Given this list of marker genes PASK, MBLAC1, NXPH3, RPS15AP30, CCDC85C (coiled-coil domain containing 85C), ENSG00000257545, LINC02777, PLCD1, LINC01213, RAB35-AS1, TMEM240, PLAGL2, RELB, CES3, ASXL2, SETDB2, CCDC12, LINC01897, VPS13D, SPATA2, ALKBH1, GRB7, RNU6-545P, SCML1, LINC01096, LIMS1, AK8, ENSG00000235978, EPN3, NDUFA3, SLC6A6, RPS4XP20, P2RX5 (purinergic receptor P2X 5), CAB39L, APC2, ENSG00000238594, SRXN1, CFL1, NEK6, RILPL2 (Rab interacting lysosomal protein like 2), SNORD13, NEMF, TKFC, RDH13, CUTC, SYNPO, RN7SL328P, DECR1, VASN, FLNB, RASL10A, GTF2F1, WDR73, LRRC43, LINC00852, RNF220, ISYNA1, ZFYVE19, LINC03000, PCDH12, STRA6, LINC02909 (NCBI Gene Id 196415, long intergenic non-protein coding RNA 2909), DNAJC6, ARHGEF10L, TSC1, SNN, MAP2K3, TEAD1, TNIP1, N4BP2L2, EARS2, TGFBI, PHETA2, KANK2, ROBO4, C1orf167-AS1, GOT1-DT, SLC29A3, PHYHD1, TTLL3, LINC01470, PRSS27, TMEM9, PEX14, MIRLET7BHG, CNN1, ISM1, ELN-AS1, PKP4P1, PABIR1, FAM193B-DT, SPTBN2, EGFL7, BAIAP2, TFB1M, RCOR3, MDGA1, CPNE2, ST6GALNAC6, SIRT1, MAP4K2, TNPO2, SIX3, RNU2-63P, GPRIN1, INPP5B-AS1, PELI3, EMID1, LINC01567, ADPRH, BBOX1-AS1, STARD3NL, NRXN1, TMEM119, STARD4-AS1, H3P14, ASAH1, RNU6ATAC18P, MTFP1, HPS4, SPG21, CPNE7, LRP8, FLRT3, MIOS-DT, RGS3, UBE2Q1, SLC2A1-DT, SFI1, LINC02971, AKR1C3 (NCBI Gene Id 96424), POLR2F, PACSIN1, CAMK1G, CDRT4 (NCBI Gene Id 94146), TNFRSF18, NUCB1, SLC2A1, KRTAP5-AS1, PRMT1, MFSD4A, NT5DC3, RPL10P12, PUM3, PTPA, HM13-AS1, PLEKHB1, STK10, PNP, FHAD1, LINC00824, CIITA, MIR378E, RNA5SP276, PHF19, MRPL53P1, GCNT2, ANKRD18DP, KIF3A, PRLR, CPHL1P, CARHSP1-DT, SEMA4F, DPP9 (dipeptidyl peptidase 9), CFAP57, SPATA20, PHC2, RPL18, TOGARAM2, SPATA17, RAD21, ATP6V1G1P6, MAP1S, ARMH1, VTRNA2-1, ABTB1, SH3BP1 (SH3 domain binding protein 1), PDXP, CCNQ, FCHO1, P2RX5-TAX1BP3, SNX29, TATDN2, SEMA4B, PKMYT1, CACNA1A, STK40, RN7SL636P, APBA3, GRIN3B, DYSF, CCN5 (cellular communication network factor 5), TJP2, INTS6-AS1, LOXL4, RHBDF1, RHOBTB2, ZBTB47, ZBTB20-AS1, INCENP, FAM174C, LINC01234, RPA1, LIFR, FSIP1 (fibrous sheath interacting protein 1), NUCKS1, RGS19, PPIA, FGFR1, ZC3H14, SPINT2, NELFB, ENSG00000276170, TNS1, PPP1R13L, LINC01132 (NCBI Gene Id 100506810), EPOP, LINC00427, AMPD3, RPL15P22, DOLPP1, NWD1, MIA, IQSEC1, SPSB1, VWA8-AS1, BCAN-AS2, BCL9L, RHOF, CDV3, PLAAT3, GTF2H4, GBA1, LINC00963, PALM, PPP1R1A, PCBP1-AS1, HSF4, TMED7, ALPL, PPM1H, NMT1, RNU6-777P, ANKS6, ROM1, C2orf72 (NCBI Gene Id 257407), DLGAP1-AS1, HIRIP3, ENSG00000259200, SUB1, CLMN, PLPP1, LDLRAP1, ESAM, ERBB3, CERCAM, SH2D3A, TPRA1, TMEM161A, VSTM2L, ARHGEF16, PRKRIP1, ANAPC5 (NCBI Gene Id 51433), BTBD19, TXNDC12, WIPF2, CYB5B, HSD11B1L, GALNT10, TM4SF1, OAS3, HPS1, LCP2, MIR365BHG, ISOC2, STARD9, CLSTN1, RIPK1, LINC01270, ARSI, ATE1, DOCK7-DT, RNU6-16P, GTPBP3, CORO1C, HSPA12A, CGB8, DDX54, TMEM229B, ZDHHC24, TMPRSS6, LINC00051, MFSD4B-DT, DHRS13, MIR27A, PTK6, C11orf68, BHLHE40-AS1, CNOT8, ENSG00000240207 (novel transcript, antisense to RARRES1), ASXL1, MIR4273, UBE2V1, UQCR11, FAM114A2, CYLD-AS1, IL7R, NRXN3, TMED7-TICAM2, LINC01633, RNU6-383P, DNAJB12, OSGIN1, PHYH, TKT, WNT4, MLH1, PDLIM1, RERE, SATB1-AS1, RNU6-560P, IFIT2, UNC13D, ACP7, MIR137HG, TEDC2, IFI27, B3GNT3 (UDP-GlcNAc:betaGal beta-1,3-N-acetylglucosaminyltransferase 3), DPPA2P4, MEGF9, PRR16, BEGAIN, TOR1AIP2, MIR4300HG, EIF2B2, CFAP119 (cilia and flagella associated protein 119), LCTL, DNM2, MTURN, LINC00598, CSRNP1, GDPD5, CAPN2, PADI2, SGSM1, POLE2, ECE1, SLC39A12, TMEM53, LPP-AS2, BRAP, CRK, DMGDH, ADAMTS14, LPP, CFAP45, CNIH3, TNFRSF10B-AS1, GMDS, PCDH1, CHDH, AKNA, FXN, PPP1R9A, RBMS1, NOL4L-DT, BMPR1B, PRKD2, ADGRG1, HIPK4, ATXN1-AS1, SLC44A4, TMEM9B-AS1, RNU6-1271P, CLK3, TMEM35B, MAN1C1, PES1P2, F2RL1, MIR4259, LINC01909, EIPR1, SNAP23, ADAMTSL5, NDUFV2, PRMT9, ZNF536 (NCBI Gene Id 9745), DVL3, LFNG, MTND4P2, GCC2, C2orf88, ABCB9, CPEB4, PTPRA, CRX, CDC42EP4, SPAG1, PHF7, RHBDL1, PPP1R14BP2, ASPHD1, LINC00856, CACTIN (cactin, spliceosome C complex subunit), NHSL1-AS1, ZDHHC12-DT, TNKS, MAML2, TMEM87A, NAIP, FXYD5, OPRL1, GPN2, APOBEC3B, PRKAR1B, PKP3, EPHB3, CENPU, REXO1, RASGRP2, KLHL17, FGFR4, SAFB, ENSG00000239093, SUGCT, TUBA1C, CDH4, SELPLG, IFT122, TRPM6, PRRT3, CD81, MDS2, RSRC1, ALDH3B1, SLC35E1, RAC1 (Rac family small GTPase 1), ARHGAP45, ZFYVE28, MIR589, RN7SL181P, MIR3189, LZTS3, KLC3 (kinesin light chain 3), RBX1, ZNF24, ETV4, TTLL5, SHKBP1, MTND4LP2, GNA15-DT, CPA5, MIR99AHG, TMC6, RANBP9, SETD1A, TCF3, SNHG5, HPN-AS1, LNX1, LMNA, ENSG00000257732, GOT2P2, FBXL19, ARF1, MIR4725, ALDH1A1, MEMO1, GRK6, LINC02749, SLC16A3, PLA2G6, PABPC1, SRRM2, DDB1, SLC25A34-AS1, GP9, PSMF1, LINGO1, SH3BP2, CDH23, VPS37D, NDUFA3P3, ITGA1, HAPLN4, KIF15, AOAH, DHX37, PTRHD1, B4GALT1-AS1, PADI4, CEACAM19, BSN, MIR4767, CTSD, GAMT, NTRK1, PRKAG2, LIPG, NMNAT1, PGPEP1, PRCD, TCTN3, NDST1, ACTA2, KHDRBS3, XPO1, NYAP1, SLF2 (NCBI Gene Id 55719), GRB10, ANPEP, RPS26P28, ANAPC1, LRRC34, DPP7, SRCIN1, PEX5, DKK3, SHD, OSBPL10, WASF2, METTL13, RABGGTA, GPBP1L1, SDC4, OLMALINC, GPATCH2, SAMD4B, KRT42P, C3AR1, SEPTIN2, AKR1C7P, G2E3, LAG3, HPN, MEG9, SIX3-AS1, SCAND3, FBN3, TEDC1, HJV, AOX1, SLCO4A1, OGG1, LINC01778, ALK, STK17B, MEGF8 (NCBI Gene Id 90198), FLII, GALNT6, SERINC5, TMEM120A, SAMD11, AOPEP, GARIN1B, NBL1, RPL27A, RBPMS, DIAPH2, MIR1238, ELOVL6, TMED10, RNF40, REX1BD, AK1, CST6, FZD4-DT, CCDC194, MYOM2, PAX5, TCP11, LINC00339, ARX, PARP15, RN7SKP140, CHN2, ACTR3B (NCBI Gene Id 57180), MCC, STAT6, EYA2, TMUB2, RN7SL449P, CYB5R3, MPRIP, RGR, ADAP2, CELF5, NKAIN4, UGCG, MELTF, SLC36A4, GAS7, CREM, CCDC22, ADAMTS9-AS1, ATIC, PLAC9P1, HLA-DPB1, PLA2G4C, TEFM, ZFAND4, RPL39P40, DENND3, IRF2BP1, MIR4672, ADTRP, PTPRU, OSBP2, HTR6, MTF1, MYL6B, LIMK2, RIN2, ATP5F1A, DENND3-AS1, WDR83, LINC01503, ITGA3, HPD, EXD3, GDF15, KSR1, PDE4A, CHCHD10, RNU5A-1, LOXL1, FERMT3, CCDC71, RITA1 (RBPJ interacting and tubulin associated 1), UPP2, CAD, RASSF8-AS1, ATP5MC1, RAB3IL1 (NCBI Gene Id 5866), FOXA3, FBLN2, KCNJ5-AS1, ZNF550, ZDHHC16, MARCHF10, DAB2IP, LMTK3, ENC1, CTDSP1, SLC25A29, LINC00592, RN7SL261P, LINC02884, TULP1, HMGA2-AS1, RARS1, PNPLA5, CTDP1-DT, PTPRS, TRAF4, HIC1, PLEKHG2, TG (thyroglobulin), RFFL, METTL14-DT, SLC7A7, DNAH11 (NCBI Gene Id 8719), HNRNPA2B1, MIR4734 (microRNA 4734), TRIM59, ZNF514, ZNF839, LINC00620, PLD3, KRT15, LSM3P4 (NCBI Gene Id 100130178), NLRP14, RPL39P38, KEAP1, IL21R (NCBI Gene Id 50615, interleukin 21 receptor), FSCN1, SCUBE1, SMAD3, LNCRNA-IUR, CAPZA1P3, LRRC8D, SCUBE1-AS1, PRR29, NR5A1, SWSAP1, NKILA, CAPN12, EPS15, RGL2, SPEG, TMEM98, PHTF1, CSF3R, CALD1, EHBP1L1, TOB1-AS1, GPR161, RNU6-810P, CGB5, BCAS4, BTG2, RNA5SP505, HM13 (NCBI Gene Id 92622), ENTPD4, NAXE, CNN2 (calponin 2), LINC02874, CBR1-AS1, EPS8L1, TM6SF1, CUX1, SMCO4, SMARCC2, DTL, PDLIM4, SLC25A37, TEK, SF3A2, PPP1R14B-AS1, CACNG5, SMUG1P1, CCL2, MSANTD3, PLEKHA6, ELANE, PHYHIP, YBX1P5, NICOL1, NELFA, POLQ, ERCC1, CDK9, SHFL, TBC1D10A, SYT3, ALDH8A1, ENSG00000226193, LST1, TRAK1, TBX6, ALDOA, UBE2L5, SCFD1, NDUFA6, MRTFB, SYMPK, SYPL1P2, MTMR9LP, MKNK2 (NCBI Gene Id 2872), TRAPPC9, SEPTIN5, MAGI2-AS3, EVA1B, KIF16B, SLC25A20 (solute carrier family 25 member 20), IL20RB, KSR2, TRIM32, SLC9A5, COLGALT1, PIGBOS1, FAM220A, ZNF234, TRIM26 (tripartite motif containing 26), TINAGL1 (NCBI Gene Id 64129), FBXO21, NEDD4L, TP53RK-DT, SRP14-DT, MIR3181, EMX2OS, DRAM1, ARHGAP40, DDX23, MACROD1, LITAF, MEIS3, PLEKHA7, ATAD1, ARHGAP27, RAPH1, EBF3, TRMT1, RARB, CIDECP1, SLC8A2, CTDP1, IMMP2L, PSMB3, CMTM8, GFI1B, COL16A1, GORASP1, FBXO17, ZGLP1, DOCK2, SYT8, EXOSC7, PEX13, IQCE, TFCP2L1, ZNF275, THUMPD2, ENSG00000256609, POLR3K, ELFN2, RNASEH2B, MYO18A, EVA1C, NFYC, PLXND1, MTND3P2, TRPV4, LINC02140, POM121, GANC, SLC7A10 (NCBI Gene Id 83251), NR2F6, SEC23IP, MTCH2P1, CCDC78, FIBIN, CADPS, PSMD13 (proteasome 26S subunit, non-ATPase 13), COL14A1, SH2D2A, MFSD4B, ARMH4, MIR23AHG (NCBI Gene Id 284454, miR-23a/27a/24-2 cluster host gene), PMVK, NDUFB7, ARVCF, MEF2B, DHRS3 (dehydrogenase/reductase 3), ANXA3, TCOF1, GPR137, INF2, PDZRN3, ITGA2B, ICAM1, ADORA1, SNX19, ATP13A2, KIAA0930, MRTO4, C1QTNF8, CACNA2D4, CFAP69 (cilia and flagella associated protein 69), NAV2, SRRD, BCL7A, ZCCHC18, FAH, MYO1B, DPP3-DT, VSTM4, AARS2, FCGRT, SLC22A18, LINC00974, COX11, GPR199P, MYO15B, STAP2, TTN-AS1, LINC00857, RPS18, ADORA2A, RPS6KL1, MT2A (metallothionein 2A), PMEPA1, ABR, MIDEAS, SIRPA, NUP153, ARHGEF1, TMCC2, PDGFRB, PELATON (plaque enriched lncRNA in atherosclerotic and inflammatory bowel macrophage regulation), KRT7, NES, RBM20, SPPL2C, PRR15, TUB, ATF7IP, TTC17, IER5, PIDD1, TFEB, GATAD2A, TMEM40, CEMIP, RPL9P21, ANKRD18B, AKT2 (NCBI Gene Id 208), TLK1, GFPT2, ZBTB47-AS1, PROSER2, MIEF1, PIANP, CSF2, GRAP2, PACSIN3, ERGIC1, RAC2, B4GALT4, ALOX5, RNA5SP305, TMEFF1, CBLN3, HNRNPA1P32, PDE4C, TNFAIP8L1, KANSL1, COL17A1, RNF14, FAM3D-AS1, MIR3681HG, PROC, HMCN2, COL27A1, HSD17B2-AS1, ZNF628, KCND1, FAM110A, CRB2, RNF44, TRPM1, ATPAF1, HGFAC, TMEM91, DOCK7, BCS1L, PLIN3, ABHD14B, MIR762HG (NCBI Gene Id 101928736), DENND2B, TECPR2, CFAP157, PRDM11, SLC8B1, DOCK6-AS1, LGR6, STH, GPR17, XRRA1, GOLGA1, KIF19, PPP2R2C, FSTL5, COA4, SDC3, TM4SF1-AS1, MCFD2, CRYBA4, TOX2, CNPY4, ASAP1, ZNF71, GTF3C1, MYLK, DEGS2, CRACR2B, EML3, ITGBL1, OSM, CDC42EP2 (CDC42 effector protein 2, NCBI Gene Id 10435), LMNTD1, SLC8A1-AS1, C3, GRK3-AS1, ARHGEF15, TLE5, TAF6L, CATSPER1, SLC38A10, PKN1 (protein kinase N1), TUFM, MIR8060, ANTXRL, ADCY1, FAM193B, BPIFB3, TPRG1, SLC4A11 (NCBI Gene Id 9574), EEFSEC, TMEM143 (NCBI Gene Id 55260), PDLIM7, EHD2, EFHC1, IFI30 (IFI30 lysosomal thiol reductase), USP35, HAPSTR1, GOLGA3 (NCBI Gene Id 2802), APRT, HDAC1, IFITM9P, KANTR, ANKRD24, SRPK1, FZD4, FAM83G (NCBI Gene Id 650803), SUCLA2, LINC02028, CASTOR1 (NCBI Gene Id 652968), QDPR, LUCAT1, PLEKHG5, CTIF (cap binding complex dependent translation initiation factor), ATG16L1, SLC12A4, RNLS, SLC39A3, TRAC, HMG20B, CD276, HENMT1, CREB5 (cAMP responsive element binding protein 5), ZDHHC12, DESI2, BTG2-DT, CYP46A1, RPL7L1, TXN, RAB42P1, ALDH7A1, EEIG1, MIR6089, PRR5, ACTN3, CNTD1, SIPA1L3, NATD1, PDE2A, ASTILCS, ATXN1, MAGED2, CYLD, SLC22A5, TMEM151A, ACTN4, PKD2L2, SLC4A5, C1QTNF5, SEMA4A, ERVK13-1, ASS1, DAP3, ITK, KIF12, EML1, SNORA70G, TYK2, ZNF579, S1PR4, SLC25A42, ZNF475, PPEF1, SSUH2, MFSD12, COQ8B, SYNGR3, FIBCD1, GEM, UBA1, RNU6-815P, MRPL34, NUDT21, SPTLC1P1, ENSG00000269172, ARID3A, ITIH4, MARK4, MYO15A, CLEC19A, TBCEL, GCSIR, CCDC159, RSPH14, HAGHL, WDR38, ERCC5, MTHFSD, BTBD9, PTK2, FBXW4, MAMDC2-AS1, ABCA7, HEXD, SPOCD1, DNAI4, GNAI2, ENTPD4-DT, TNIK, MIR23A, PKD2L2-DT, PLEKHM1, MAP3K11, MTCL2 (NCBI Gene Id 90072), DUSP10 (NCBI Gene Id 11221), TCEA1, SNORA63, NIPAL4-DT, GTF2IRD1, SPHK2, GALE, BRD2, PRKACA, MAST3, DPF1, CALM1, MIDN, SAMD14, ZNF474, RPS25P3, KXD1, TTYH2, PEAR1, MEAF6P1, NPHP4, LINC01936, PGLS, LINC02298, UBE2CP2, POLM, FILIP1L, VARS2, FBXO2, KANK3, AIFM3, TSPAN18, GMFG, SNRNP25 (small nuclear ribonucleoprotein U11/U12 subunit 25), CALM3, CATIP-AS1, TRAPPC3, TESC, KLF11, ANAPC15, PRR22, IL12RB1, PDLIM5 (NCBI Gene Id 10611), TIGD1, NDUFS5, CEP295NL, PEPD, NCOR2, TAGLN, ECH1, AHCY, SLC30A3, GUF1, TIGD2, PBX1, NIPSNAP1, RNU2-72P, MIR4425, RPL13P2, GFER, RAB14, ADAMTSL4, ECHDC2, CAND2, ITPKB-AS1, PMCH, PRR5-ARHGAP8, RNU6-664P, EMC2, METTL14, MTCO1P2, RBMS3-AS3, BMP7, SLAMF8, CDC5L, SIRT6, SUPT4H1, NDUFB10, PAK4, BZW1, CELSR1, LILRB1, FOCAD (focadhesin), C17orf99, PIK3R2, SPATA3-AS1, TSSC4, SRC, HSPB7, LINC01068, ZMIZ1, ENSG00000259182, ZNF746 (NCBI Gene Id 155061), ZNF668, CNGB1, TRIOBP, RNU7-124P, ADAT3, MIR4276, SMYD4, RNA5SP180, PLEKHG7, RNU4ATAC11P, SPRYD7, SSC5D, PPP1R10P1, CDK19, PHLDA2, PIM3, HSPB1P2, SASH1, RPL12P25, COX6CP5, TRIB3, SYTL1 (NCBI Gene Id 84958), SLC7A6, CHRD, PTPN1, WARS1, EFNB3, HACD4, MVB12A, SMAGP, FSD1, RNH1, ARPC4, SLC4A3, AKT1, SNAPC2, FBXO44, KISS1R, ELOVL1, GPR35, IGSF21, VAMP5, STARD10, ITGB4, BHLHE22-AS1 (NCBI Gene Id 401463), URAHP, LSP1, PDE4B, EEF1A1P32, ZDHHC3, GADD45B, ENSG00000232900, MIR6745, POLR1G, PPP1R14B, CCDC178, ENSG00000258702, MAD1L1, ENSG00000229425, ATG4D (NCBI Gene Id 84971), SCAMP4, EMP1, TESC-AS1, GEMIN4, PRKCD, NMRK2, ACTR10, CASTOR3P, CERKL, ARPC4-TTLL3, OTUB1, DNAJC17, RPL29P6, AXL, NKD1, SLC23A1, VMP1, DCTPP1, ACY1, MSN, AZIN2, TGFBR2, SIRT3, APBB2, RPL13AP27, TMC8, HGSNAT, SMASR, EFCAB12, FAM174B, SCHIP1, SEMA6B, PPP1R7, ADAMTS18, C19orf25, RNU7-88P, PLD4, POLD4, CDC42BPG, MMP2, MIR345, PACS2, PLAUR, SPRY4-AS1, ANKS1B (NCBI Gene Id 56899), MAFK, CDH6, NT5C2, GPR107, ADGRB2, MIR548AW, PPP2R2A, C14orf119P1, NIFKP9, KIAA1671, PGK1, TJP3, NLRP1, DHX16, CPSF1, OPA3, RANBP17, POLDIP3, ZNF606, NAE1, PNPLA6, ZSCAN25 (zinc finger and SCAN domain containing 25), CNTN2, RMND1, STING1, ARAF, COASY, KANSL1-AS1, SIGLEC1, RPL35AP6, OR4E2, NINJ2, MLLT1, RNU6-1066P, CRISPLD2 (NCBI Gene Id 83716), TMEM59L, PLCXD2, DNMT1, NCKAP5-IT1, IL31RA, DNHD1, DHCR24, CROCC, LRRC25, P2RY6, ACVR1, ATP6V0E2, EXOC7, PPARGC1B, RASAL1, CFAP73, CYGB, RIN3, TPM4, MFNG, SCN8A, MAMDC2, CDC25B, TMEM9B, NLRX1, MDFI, EDEM3, RPL6P28, ARIH2, SEPTIN9-DT, CARHSP1, LRRC4C, FURIN, WNT5A, PLOD1, ACOT8, KCNIP1-OT1, COX17P1 (NCBI Gene Id 81993), NCAN, NOTO, FBXW2, ATP2C2, PCNX1, WHRN (whirlin, NCBI Gene Id 8016), TTLL7, CCDC117, TDRD10, ATP5F1D, UBFD1 (ubiquitin family domain containing 1), ZNF737, GTF2E1, KCNN1, LONP1, LINC00323, MIR3619, IL1RAP, LINC03122, DRAP1, BBC3, LASP1, TMEM125, TRMT61B, CA9, TMEM200B, TPST2, SLC15A3, OCEL1, NAA35, DIO2, LSR, RASL12, BAIAP2L2, KISS1, NFIC, RNU7-140P, RBMS3, GLP2R, ARHGEF19, CTSA, GPX8 (NCBI Gene Id 493869), TTI2, SEPTIN9, CREBRF (NCBI Gene Id 153222), QKI, KIAA1755, PDE7B, TTC39A, MIR4497, PLPP3, NR6A1, USP3-AS1 (NCBI Gene Id 100130855), MIR4487, TAF6, NEDD1, SSBP3, LINC01775, TGFBR3L, SUSD3, CXXC5, RPSAP75, NCOA6, RAB27A (RAB27A, member RAS oncogene family), OVOL1, TLE6, RAI1, LINC02447, PC, SH3KBP1 (NCBI Gene Id 94010), ADGRG6, SH2D5, SEMA3F, EWSAT1, QPCT (glutaminyl-peptide cyclotransferase), SHOX2, KIAA0319, LINC02323, DPP3, SLC43A1, ERAS, CBX1P3, CYTH4 (NCBI Gene Id 29776), SCNN1A, RPS27AP7, DOK4, TEX38, MIR1302-7 (NCBI Gene Id 100302147), SERBP1P1, NUAK2, LINC00649, BCL11B, RBM47, here is a description of the gene set: Human Gene Set: ZNF92_TARGET_GENES studied in species Homo sapiens from publication Yevshin I, Sharipov R, Kolmykov S, Kondrakhin Y, Kolpakov F (PMID 30445619) Genes containing one or more binding sites for (ZNF92) in their promoter regions (TSS -1000,+100 bp) as identified by GTRD version 20.06 ChIP-seq harmonization.